Given this list of marker genes NOS2 (NCBI Gene Id 4843), rpoZ, secA1, ATP6V1H, oppB, UBB, cpnT, MAPK3, rpoB, Rv2895c, esxH, aldR, esxA, rpoA, UBA52, eis, MAPK1, LTF, GSK3A, sodC, B2M, trxB, MRC1, adhE2, secG, UBC, Rv3364c, Rv1410c, RAB7A, esxG, PPE2, pstS1, secA2, oppD, rpoC, SFPQ, bfr, HGS, bfrB, msrA, Rv3655c, ndkA, secE, oppA, secD, trxA, trx-2, DUSP16, fgd1, VPS33B (NCBI Gene Id 55513), lpdC, TRIM27, RNF213 (NCBI Gene Id 79398), irtA, ahpD, ptpA, secF, tpx, PGK1, KPNB1, ggtA, secY, TLR2, lprG, CTSG, ahpE, RPS27A (NCBI Gene Id 6233), RAB5A, Rv3654c, CORO1A, ahpC, irtB, sodB, ENO1 (enolase 1), sapM, glbN, MT2748, dlaT, lprM, katG, oppC, KPNA1, here is a description of the gene set: species: Homo sapiens Reactome Pathway: Infection with Mycobacterium tuberculosis Infection with Mycobacterium tuberculosis (Mtb) is soon countered by the host's immune system, the organism is however almost never eradicated; ten per cent of infections will develop into "open tuberculosis", while the other ninety per cent become "latent", a state that can persist for decades until loss of immune control. Approximately 25% of the world's population is estimated to harbour latent tuberculosis. Latent infection involves the bacterium being internalized by phagocytes where it stops and counters the innate immune answer. When a status-quo is reached, Mtb enters a non-replicating persistent state. Weakening of the immune defense sooner or later enables the waking up and multiplication of the bacterium inside the phagocyte, necrosis of the cell, and escape, analogous to the burst of lytic viruses. part of: Bacterial Infection Pathways